The following is a description of a gene set: Mouse Gene Set: GOBP_CILIUM_MOVEMENT The directed, self-propelled movement of a cilium. species: Mus musculus, and this is the list of marker genes: Clxn, Spef1, Prss55, Drc1, Ccnyl1, Cfap90, Atp1a4, Garin5b, Spmip8, Adam3, Prdm14, Cfap97d1 (NCBI Gene Id 75437), Dnah7a, Dnah7c, Spef2, Rabl2, Cfap69, Saxo4, Cfap206, Slirp, Nme7, Tekt5, Cep128, Iqub, Insl6, Akap4, Txndc2, Vangl1, Ropn1l, Odad1, Aqp4, Cwh43, Dnaaf1, Ash1l, Ccdc65, C2cd6, Qrich2, Ttll9, Spmip9, Drc7, Spag6l, Garin5a, Dnaaf6, Cabs1, Dusp3, Cfap70, Cep78, Prm3, Tekt3, Rnase10, Pdcl2, Dusp21, Cfap61, Armc3, Tcte1, Ttc12, Bbs1, Pgk2, Cfap45, Dnai4, Kif3a, Dnah5, Ccdc38, Fsip2 (NCBI Gene Id 637858), Dnai3, Dnah10, Dnah7b, Dnali1, Lztfl1, Tacr1, Apob, Tmem232, Efhb, Ccdc39, Tac1, Spmip10, Cfap161, Katnip, Tektl1, Dnah2, Camsap3, Cyb5d1, Gas2l2, Pla2g3, Tacr3, Spaca9, Taf7l, Spinkl, Spem3, Tekt1, Spmip6, Cimip2b, Dnai1, Ccdc103, Rfx3 (NCBI Gene Id 320548), Ing2, Cfap298, Tac4, Tac2, Rsph3b, Pacrg, Dnaaf2, Odad3, Yif1b, Ccr6, Catsper2, Cfap95, Ofd1, Adcy10, Dnaaf6rt, Cfap57, Gmnc, Dync1h1, Dnai2, Tuba1a, Dnah3, Cfap276, Catsper4, Celsr2, Garin3, Spem1, Hydin, Cfap65, Tubb4b, Slc9b1, Defb1, Dnah1, Spag17, Catspere2, Ddx4, Dnaja1, Ttll3, Ribc2, Mst1, Dnaaf4, Daw1, Tex101, Dydc1, Spag6, Vps13a, Dzip1, Efhc1, Mns1, Rnase9, Dnhd1, Cacna1e, Nherf1, Cfap141 (NCBI Gene Id 73545), Dnaaf5, Smcp, Ccdc88c, Rsph4a, Dpcd, Gk2, Ccdc40, Ttll5, Akap3, Tnp2, Ints13, Tekt2, Ttc29, Zmynd10, Ttll8, Dnah6, Ttll6, Eno4, Cfap144, Bbof1, Catsper1, Efhc2, Cep131, Rsph9, Or4m1, Defb37, Iqcg, Neurl1a, Ldhc, Tacr2 (tachykinin receptor 2), Ift81, Dnaaf11, Enkur, Dnah12, Slc22a16, Gapdhs, Ly6k, Pierce2, Tpgs1, Lrrc46, Garin2, Dnah17, Ttc21a, Chrna7, Dnaaf3, Iqcn, Cfap20, AU040320, Cfap119, Nphp4, Anxa5 (NCBI Gene Id 97115), Ttll1, Dnah8, Rsph6a, Wt1, Invs, Nme5, Kif27, Dnajb13, Tssk6, Slc9b2, Met, Atp2b4, Tmf1, Cfap44, Eppin, Spata33, Sord, Cfap68, Iqcf1, Misfa, Slc22a14, Rsph14, Vdac3, Rsph1, Ribc1, Ccdc159, Adam7, Meig1, Lrrc23, Dnah14, Inpp5b, Nek10, Wfdc6b, Slc9c1, Tektip1, Cfap58, Megf8, Pierce1, Jhy, Armc12, Cimip2c, Dnah11, Ube2b, Spag16, Cabcoco1, Irgc, Rgn, Celf3, Adcy3, Gas8, Bbs4, Cfap47, Tppp2, Dnah9, Catspere1, Ak7, Cfap126, Rhox5, Tekt4, Cfap43, Ulk4, Armc2, Spag8, Cfap251, Cfap210, Cfap100, Nme8, Poc1b, Bbs2, Zmynd12, Pfn4, Cfap53, Catsper3, Cfap73, Wfdc6a, Catsperd, Tbc1d21, Ccdc63, Odad2, Efcab6, H1f6, Mkks (McKusick-Kaufman syndrome), Cfap107, Nsun7, Stk36, Odad4, Cfap221, Cimap1a, Tnp1, Ropn1, Cimip2a, Cfap54, Ift88, Catsperz, Kif9, Klc3, Hoatz, Cfap157, Ccdc146, Tssk4, Spmip5, Pldi, Pltp (phospholipid transfer protein), Efcab9, Septin4, Cfap52, Dync2h1, Cfap91, Stard7